The following is a description of a gene set: species: Homo sapiens Genes predicted to be targets of miRBase v22 microRNA hsa-miR-6823-3p in miRDB v6.0 with MirTarget v4 prediction scores > 80 (high confidence targets). from publication Chen Y, Wang X (PMID 31504780) Human Gene Set: MIR6823_3P, and this is the list of marker genes: RAB3B, ZMAT5, DPP10, SENP2, SMPD3, TMEM167B, RTN4RL1, HIF3A, HNRNPU, APH1A, ARL11, CTDNEP1, CHRNE, LILRA2, TNKS, FAM168A, MEAF6, C20orf203, VAMP1, TSPAN3, SPAG8, S100A7A, ITPR1, ERCC1, STK4, MEF2C, DKK3, RHO (rhodopsin), PRR3, PSMC3IP, STON2, CTBS, PPFIA2, CNNM1, TBR1, AGFG1, RHCG, LIMCH1, DHX58, NLK, EMB, MTMR3 (NCBI Gene Id 8897), YAF2, MMAB, DCP2, CSMD1, GRIN3A, LBH, CXCL12, BCAS1, LARP1B, TOP3A, SIGLEC1, ELOA, BIRC6, AGTR2, KPNA6, SPIN1